The following is a description of a gene set: The series of molecular signals mediated by the endoplasmic reticulum membrane stress sensor PERK (PKR-like ER kinase). Begins with activation of PERK in response to endoplasmic reticulum (ER) stress and ends with regulation of a downstream cellular process, e.g. transcription. The main substrate of PERK is the translation initiation factor eIF2alpha. Serine-phosphorylation of eIF2alpha by PERK inactivates eIF2alpha and inhibits general protein translation. In addition, eIF2alpha phosphorylation preferentially increases the translation of selective mRNAs such as ATF4 (activating transcription factor 4), which up regulates a subset of UPR genes required to restore folding capacity. species: Mus musculus Mouse Gene Set: GOBP_PERK_MEDIATED_UNFOLDED_PROTEIN_RESPONSE, and this is the list of marker genes: Akt2, Akt3, Igtp, Hspa5, Ptpn2, Bok, Ptpn1, Qrich1, Tmed2 (NCBI Gene Id 76322), Nck1, Nck2, Akt1 (NCBI Gene Id 268604), Abca7, Eif2ak3, Eif2s1, Rpap2, Ddrgk1, Agr2, Tmem33, Atad3a, Nfe2l2, Atf4